Given this list of marker genes GPR83, BMP2, TNFSF10, DENND5A, PTRH2, CD86, BMPR2, PTH1R, CD79B, PLPP1, SNX9 (NCBI Gene Id 51429), TRAF1, DRC1, IL1RL1, CISH, EEF1AKMT1, CD81, HOPX, FURIN, CTSZ, AMACR, SMPDL3A, AHCY, COCH, CCND2, PNP, COL6A1, PRAF2, MUC1, IL10RA, UCK2 (NCBI Gene Id 7371), CSF1, SOCS1, TLR7, SLC39A8, DHRS3, BCL2L1, GADD45B, PLAGL1, HUWE1, NCOA3, SHE, FAH, PTGER2, IL2RA, IKZF4, GLIPR2, ETV4, IFNGR1, NT5E, KLF6, LIF, TNFRSF9, PRNP, RNH1, TNFSF11, ABCB1, NRP1, SYT11, RGS16, ST3GAL4, S100A1, NOP2, CDC6, TNFRSF1B, LRIG1, IL2RB, PRKCH, PIM1, ITGAV, CTLA4, TNFRSF4, WLS, ALCAM, CASP3, SPRY4, CDKN1C, IL10, TNFRSF8, FGL2, HK2, DCPS, SOCS2, ICOS, P2RX4, ODC1 (ornithine decarboxylase 1), GABARAPL1, GBP4, CD48 (CD48 molecule), SERPINB6, BHLHE40, IL18R1, IGF2R, HIPK2 (homeodomain interacting protein kinase 2), BATF, MAPKAPK2 (MAPK activated protein kinase 2), CSF2, PTCH1, ITGA6, TGM2, ARL4A, EOMES, MYO1C, RABGAP1L, SPP1, IL4R, MAP6, CCNE1, TIAM1, CDC42SE2, CDCP1, MYC, NDRG1, LRRC8C, HYCC2, CCR4, CKAP4, PLSCR1 (phospholipid scramblase 1, NCBI Gene Id 5359), CCND3, IRF4 (NCBI Gene Id 4592), AHR, SELL, ANXA4, LTB, IL13, NCS1, PHTF2, IL1R2, APLP1, RHOB, ITGAE, BCL2, MXD1, F2RL2, CA2, GATA1 (NCBI Gene Id 2623), TTC39B, RORA, PHLDA1, IL3RA, MAP3K8, FLT3LG, PUS1, ENO3 (enolase 3), EMP1, IRF6, ENPP1, LCLAT1, MYO1E, CAPG, GALM, RRAGD, SPRED2, BATF3, MAFF, SLC1A5, UMPS, XBP1, GUCY1B1, SH3BGRL2, PLEC, TNFRSF18, SCN9A, CST7, CD83, P4HA1, TWSG1, IKZF2, ITIH5, NFIL3, GPX4, CYFIP1, TNFRSF21, IGF1R, RHOH, SLC29A2, CXCL10, PENK, SLC2A3, ECM1, ADAM19, POU2F1, CD44, AHNAK, GSTO1, NFKBIZ, IFITM3, AGER, GPR65, PLIN2, ETFBKMT, SWAP70, SELP (selectin P), SYNGR2, PDCD2L, SNX14, CAPN3, SERPINC1, IRF8, here is a description of the gene set: Human Gene Set: HALLMARK_IL2_STAT5_SIGNALING studied in species Homo sapiens from publication Liberzon A, Birger C, Thorvaldsdóttir H, Ghandi M, Mesirov JP, Tamayo P (PMID 26771021) Genes up-regulated by STAT5 in response to IL2 stimulation.